The following is a description of a gene set: species: Mus musculus Mouse Gene Set: REACTOME_SEALING_OF_THE_NUCLEAR_ENVELOPE_NE_BY_ESCRT_III Sealing of the nuclear envelope (NE) by ESCRT-III, and this is the list of marker genes: Tuba3a, Tubb4a, Tuba3b, Vps4a, Tuba8, Spast, Chmp2b, Tuba4a (NCBI Gene Id 22145), Tuba1b, Tubb2b, Tubb2a, Tubal3, Tubb3 (NCBI Gene Id 66927), Chmp6, Chmp4c, Tubb6, Cc2d1b, Ist1, Tuba1a, Chmp7, Tubb1, Chmp4b, Chmp2a, Chmp3, Tubb4b, Tuba1c